The following is a description of a gene set: Electromyographic (EMG) findings characteristic of axonal neuropathy, with normal or slightly decreased nerve conduction velocities, normal or slightly prolonged distal latencies, but significantly reduced motor potentials and sensory amplitudes. There may be spontaneous activity upon needle EMG studies, such as increased insertional activity, positive sharp waves, and fibrillation potentials. Human Gene Set: HP_EMG_AXONAL_ABNORMALITY species: Homo sapiens EMG: axonal abnormality, and this is the list of marker genes: PDK3, MTMR14, CYP27A1, SETX (NCBI Gene Id 85506), ATP13A2 (NCBI Gene Id 63919), SPG11, SGCG, NR4A2, ANXA11, DNM2, LMNA, OPTN, TFG, GNE, ANO5